The following is a description of a gene set: Megalocornea An enlargement of the cornea with normal clarity and function. Megalocornea is diagnosed with a horizontal corneal diameter of 12 mm or more at birth or 13 mm or more after two years of age. Human Gene Set: HP_MEGALOCORNEA species: Homo sapiens, and this is the list of marker genes: PRDM5, CDH11, CLIP2 (CAP-Gly domain containing linker protein 2), LIG4, MT-CYB, POMK, BUD23, FGFR2, KCNMA1, GTF2IRD2 (GTF2I repeat domain containing 2), LTBP2, PIK3R1, TINF2, TMEM270, CTBP1, PPP2CA, DNAJC30, MAF, ELN, CPLX1, POMT2, GMPPB, NCF1, NELFA, FKTN, LARGE1, KIFBP (kinesin family binding protein), FGD1, NSD2, TEK, BAZ1B, MYOC, NSUN2, VPS37D, LETM1, CHRDL1, GNPTAB (N-acetylglucosamine-1-phosphate transferase subunits alpha and beta), GTF2IRD1, POMGNT1, SH3PXD2B, EIF4H, LIMK1, COL11A1, ANTXR1, METTL27, CYP1B1, FBN1, STX1A, POMT1, RFC2, GTF2I, FKBP6, TBL2, PITX2, PIGG, FKRP